The following is a description of a gene set: Any process that stops, prevents or reduces the frequency, rate or extent of an ATPase-coupled calcium transmembrane transporter activity. species: Mus musculus Mouse Gene Set: GOBP_NEGATIVE_REGULATION_OF_ATPASE_COUPLED_CALCIUM_TRANSMEMBRANE_TRANSPORTER_ACTIVITY, and this is the list of marker genes: Sln, Smim6, Mrln, 1810037I17Rik, Tlr9, Pln, Zfas1